Given this list of marker genes UACA, APIP, XIAP, CYCS, CASP9, CASP3, AVEN, CASP7, DIABLO, APAF1, MAPK3, MAPK1, CARD8, here is a description of the gene set: species: Homo sapiens Reactome Pathway: Cytochrome c-mediated apoptotic response Upon its release from the mitochondrial intermembrane space, cytochrome c (CYSC) binds to and causes an ATP-mediated conformational change in the cytoplasmic adaptor protein apoptotic protease‑activating factor 1 (APAF1). This conformational change triggers the formation of procaspase-9-activating oligomeric protein complex named apoptosome. The active caspase‑9 holoenzyme activates downstream effector caspases‑3 and ‑7. The activated effector caspases then cleave various cellular proteins. part of: Apoptotic factor-mediated response